Given this list of marker genes Krtap28-13, Sbspon, Bmpr2, Rab9, Copb1, Fntb, Chodl (NCBI Gene Id 73211), Tm6sf1, Speer4d, Klhl24, Crkl, Bmp5, Clec4e, Rtn4, Slco1a1, Inpp4b, Fam174a, Zfp407, Timeless, Cul3, Cttnbp2, Ndufb5, 2210408I21Rik, Mapk10, Meikin, Fbxo45, Cnot6l, Ccser2, Tbc1d8b, Tex101, Gk, Kdm2a, Parpbp, Klhl9, Vsx2, Sfr1, Prex2, Ankdd1b, Tmed5, Zbtb1, Cntn3, Ccl11, Chpt1, Akap6, Lrrc4, Mgat2, Lrrtm2, Tmf1, D16Ertd472e, Slc6a1, Utp23, Arl4a, Sp4, Ltn1, Ppa1, Cpeb2, Pop1, Zic2, Grik2, Cilk1, Gpm6b, Naa50, Tent4a, Ankra2, Kbtbd3, Sbno1, Bmt2, Spin4, Pdcl2, Dph6, Fign, Skil, Spopl, Elp4, Ythdc2, Usp6nl, Cbll1, Ric1, Mindy2, Ube2n, Mbnl1, Nr2c2, Dennd5b, Usp13, Kras, Tead1, Ppm1k, Ntaq1 (N-terminal glutamine amidase 1), Hacd2, Fgf16, Mindy3, Kat6a, Kdm5a, Pigm, Steap2, Rpgrip1l (NCBI Gene Id 73313), Rc3h2, Adam20, Fez2, Nadk2, Hcn1, Mtmr6, Cysltr1, Pcdhb3, Gpr22, Ipp, Dlx1, Zfand5, Kcnj16, Avl9, Nfib (NCBI Gene Id 77183), Gnpnat1, Ythdf3, Fat3, Tpk1, Zbtb26, Larp4b, Snx13, Nrxn1, Parp4, Chek1, Dnajc28, Hus1 (NCBI Gene Id 15574), Immp2l, Osbpl8, Cyp2j13, H1f0, Hao2, Krtap13-22, Rnf128, Rad21, Foxi2, Col4a3, Tm9sf3, Ankrd40, Dpy19l3, Brip1, Mrpl1, Csde1, Ate1, Six1, Trpc1, Atrnl1, Six2, Dido1, Edem3, Tmem11, Csad, Rap1a, Snx24, Ccn1, Galnt3, Ociad2, Taf4b, Hycc2, Nampt, Dipk2a, Zfp800, Cdc37l1, Fam199x, Ptchd4, Lrrc39, Elmod2, Slc10a6, Phip, Or5m3b, Pclaf, Manea (NCBI Gene Id 242362), Camk2d, Fhl2, Erlin1, Egr4, Spdl1, Dclre1a, Dlg1, Sim1, Vps4b, Chl1, Them7, Rif1, Snrnp70, Btk, Crebrf, Rock1, Sst, Eya1, Tmem230, Rpl22, Defb4, Ctsc, Rit2 (Ras-like without CAAX 2), Lig4, Prtg, Mon2, Ehhadh, Gda, Paip1, Arhgap21, Lrp8, Flrt2, Zdhhc21, Stag2, Gria2, Ppm1d, Cdc73, Echs1, Arl5a, Asph, Plekha1, Tmem167, Spire1, Srpk2, Zfp329, Chst2, Sowahc, H2bc21, Prl3d1, Deptor, Clca3b, Btbd3, Kat2b, Eri2, Adam22 (NCBI Gene Id 72849), Tafa2, Apaf1, Gpr34, Trp53bp2, Myo19, Csmd1, Eeig1, Rbms3, Fut9, Brsk2, Fut10, Mef2a, Spi1, Tor1a, Cd200r4, Tes, Sycp1, Rc3h1, Zfp131, Tshz1, Fasl, Gabpa, Pof1b, Mcm5, Snap25, Mgarp, Ola1, Ppp2r2c, Speer4c1, Adipor1, Camta1, Tom1l1, N4bp2l2, Klri2, Tcea1, Stxbp6, Casp3, Stard4, Lipi, Uap1, Lox, Tmem236, Rab11fip2, Commd2, Lats1, Snca, Ttbk2, Gid4, Larp4, Cep135, Kdm7a, Mecp2, Aldoc, Nxt2, Syde2, Tfrc, Zscan26, Zzz3, Fsd1l, Arid4b, 2310002L09Rik, Arhgap18 (Rho GTPase activating protein 18), Abhd5, Wnk3, Prkg2, Wasl, Kdm4c, Lsg1, Rrh, Dnaja4, Kcnip4, Gemin4, Chic1, Cd84, Fam169a, Gca, Zbtb34, Rnf34, Hsd17b7, Mllt10, Taf1, Smad2, Fam120a, Zdbf2, Tspan2, Nrk, Rrm2, Mmut, Hormad1, Gtf2a1, Cdc14a, Ptbp2, Usp38, Dennd4c, Mllt3, Wt1, Fndc3a, Ttpa, Bicd1, Serinc1, Aebp2, Tmx4, Col5a1, Isoc1, Stam, B3galt2, Celf2, Dhx16, Acer3, Ecscr, Jmjd1c, Trpc7, Dennd1b, Ncoa2, Fbxo43, Ino80d, Zfp287, Ska1, Pcgf6, Marchf5, Hace1, Mga, Scn2a, Lrat, Elf1, Med13, Scaf11, Ints2, Gjb2, Acyp2, Tmprss15 (NCBI Gene Id 353032), Pdc, Nwd1, Slc8a1, Nox4, Ptprc, Snx18, Fezf2, Cep57l1, Syncrip, Mmp20, Eif5a2, Slc35f4, Zswim6 (NCBI Gene Id 67263), Abhd10, Sp3, Ccdc88a, Spib, Hs3st5, Mdfic, Map2, F13b, Rp2, Clock, Hectd2, Got2, Ift56, Tgtp2, Cnr1, Prrg1, Bivm, Nipsnap3a, Pikfyve, Bdnf, Lancl2, Fam118a, Xpo1, Nrip1, Arsk (arylsulfatase K), Spin1 (spindlin 1), Fmo2, Elovl5 (NCBI Gene Id 68801), Laptm4b, Rab39, Ndufb3, Cadm2, Epb42, Slc25a46, Azi2, Mfsd14a, Zcchc9, Zfp281, Ncoa1, Plcxd2, Cpne1, Dpyd, Rmnd5a, Grxcr2, Homer1, Mbnl3, Evi5, Mysm1, Zfp507, Prdm2, Bltp3b, Gnas, Alcam, Fam135a, Ddx46, Gabra4, Dmxl1, Ptbp3, Slc35b3, Cfap69, Abcb7, Col10a1, Smad4, Pdp1, Hsbp1l1, Or4n5, Nap1l5, Thoc2, Gtf2h4, Smim17, Pdia5, Scai (suppressor of cancer cell invasion), Unkl, Fgd4, Shprh, Drd1, Fignl1, Cox15, Prkg1, Gm6878 (predicted gene 6878), Plppr5, Spata13, Gxylt1, Slit2, Cacna2d1 (calcium channel, voltage-dependent, alpha2/delta subunit 1), Tank, Atxn7, Uty, Terf2ip (NCBI Gene Id 57427), Macir, Abcd2, Ccdc126, Sos2, Slc4a4, Arhgef9, Npl, Tas1r3, Samd7, Pi4k2b, Tut4, Rgs5, Il4ra, Atm, Chmp1b, Ubr3, Ppig, Pcgf3, Sclt1, Slc22a4, Setdb2, Rfx3, Col5a2, Tob1, Stxbp5, Aifm3, Ppp1r21, Nck1, Stard13, Map3k5, Zfp280d, Scn1a, Igf1, Aff4, Erbb4 (erb-b2 receptor tyrosine kinase 4), Kif14, Ccnc, Wdr26, Usp37, Lysmd3, Zfp747, Arl13b, Dync1li2, Nbeal1, Lrrc19, Ocln, Cipc, Serpinb1b, Prkacb, Oxr1, Ppp1r14bl, Enkd1, Unc80, Sult3a1, Slc25a16, Sar1a, Sema3c, Pcdh17, Syt4, Septin12, Mill1, Gucy1a2, Chrnb1, Synj2bp, Tmx3, Tmem209, Gkap1, Top1, Vcan, Fen1, Khdrbs1, Zfp456, Hsf3, Plgrkt, Zmynd11 (NCBI Gene Id 66505), Sec24a, Zfp160, Pogk, Ndnf, Bod1l, Bcar3, Pln, Tmem65, Gpr174 (NCBI Gene Id 213439), Trio, Ngdn, Mdm1, Golgb1, Scp2, Oaf, Slc22a19, Tbc1d9, Esco2, Rnf14, Edil3, Pds5b, Acvr2a, Btf3l4, Kcnv2, Aspn, Col24a1, Mbtd1, Pi15, Gas2, Aqp7, Naa15, Tulp4, Cdk12, Atp10b, Mymx, Camk4, Gadl1, Tmem229a, Ankib1, Cltrn, Hlf, Ppp1r3a, Mtmr4, Slitrk5, Adgrf2, Hmcn1, Usp43, Muc15, Pnn, Tmem106b, Sprr1b, Tmprss11e, Olfm3, Tcf20, Stk39, Lpar4, Shox2, Degs1l, Cdk19, Thsd7a, Nr2f1, Eif5, Atp8b5, Clec4d, Tgtp1, Cdh19, Ppp4r3a, Arf6 (NCBI Gene Id 11845), Lypla2, Papss1, Asb15, B3gnt2, Klhl2, Grb14 (growth factor receptor bound protein 14), Sema3d, Sparcl1, Cyfip1, Adgrl4, Dlk2, Galnt1, Akr1e1, Nepn, Ncstn, Adamts9, Crebzf, Mreg, Ctbs, Kcnt2, Tmem9b, Tyr, Dhdh, Slc17a6, Aktip, Cep76, Polk, Cbfb (core binding factor beta), Henmt1, Ttc9, Stim2, Dap3, Tnrc6b, Twf1, Dlx5, Cenpj, Bcl7b, 1110032F04Rik, Gfm1, Gh, Pcdh20, Ext2, Htra2, Plp1, Alpi, Cdh12, Dpp4, Tmem255a, Mab21l2, Ankrd33b, here is a description of the gene set: Genes predicted to be targets of miRBase v22 microRNA mmu_miR_590_3p in miRDB v6.0 with MirTarget v4 prediction scores > 80 (high confidence targets). Mouse Gene Set: MIR_590_3P from publication Chen Y, Wang X (PMID 31504780) species: Mus musculus